The following is a description of a gene set: Part of the cilium where the axoneme ends. The ciliary tip has been implicated in ciliary assembly and disassembly, as well as signal transduction. species: Homo sapiens Human Gene Set: GOCC_CILIARY_TIP, and this is the list of marker genes: IFT70B, CDKL5, TTC21B, KIF3C, SMO, IFT46, DYNC2I2, IFT25, DYNLRB1, IFT172, DYNC2H1, DYNLL1, RP1, DYNLRB2, ODAD3, IFT52, IFT27, GLI1, KIF3A, GLI3, IFT56, IFT80, ARMC9, WDR35, KIF3B, GLI2, DYNLL2, ULK3, IFT122, IFT140, DYNC2I1, IFT74, KIF7, IFT81, IFT43, CLUAP1, DYNC2LI1, SUFU, IFT20, IFT88, CILK1, IFT22, CYLD, IFT57, KIFAP3, WDR19, TRAF3IP1, SPEF1